The following is a description of a gene set: studied in species Homo sapiens A wavelike sequence of involuntary muscular contraction and relaxation that passes along a tubelike structure, such as the intestine, impelling the contents onwards. Human Gene Set: GOBP_PERISTALSIS, and this is the list of marker genes: TBX2 (NCBI Gene Id 6909), P2RX2, P2RX3, NEUROG1, DRD2, TBX3, GDNF, DRD1, TIFAB, DLG1, DCANP1